Given this list of marker genes MACROH2A1, FANCM, ADAMTS3, SLCO5A1, ZFYVE27, IKBKB, ATAD5, CKAP2, DHFR, MRPL51, UBR5, MRPL20, UBE2T, API5, AKAP5, SMC2, TMPO, KRBOX1, NCAPG, DNTTIP2, XRCC3, ZNF330, ERCC1, HJURP, TOP2A, DLGAP5, MSH5, MTERF1, NDUFA9, CHAF1A, WDR83OS, CDKN3, MND1, RPS26, RGS6, PCDHB5, ZNF532, LAMA1, POLE2, HAND2, ESPL1, RGS16, ODF2, ITFG2, LSS, SGO2, ZWINT, PARPBP, GIT2, KIF15, RBMY1A1, INF2, CCT6A, SAP30, ANLN, SPC25, HYCC1 (NCBI Gene Id 84668), ERH (NCBI Gene Id 95660), MRPL42, RPA3, CENPF, GJC1, HMGB2, PINX1, MACIR, TGFB3, PSIP1, CDC6, RIC8B (NCBI Gene Id 55188), DAP3, TCOF1, SPCS3, CCNA2, ZNF93, FGFR1OP2, ATAD2, CHEK1, RBM17, LARP4, ZNF146, FANCD2, BRIP1, ARHGAP11A, CTPS1, HOMER1, PRPF40A, OR2A4, PCLAF, PSTPIP1, NAA15, KIF2C, PPP4R3A (protein phosphatase 4 regulatory subunit 3A), DBF4, CEP55, SNRPD3, NAMPT, EAF1, RGS1, LMNB1, H2AZ1, XPO4, C4orf3, CSRNP1, KPNA2, ANK2, WDHD1, PTTG3P, HMGN2, PAG1, MELK, BRD9, GMNN, CLPTM1L, SDCBP, CENPK, PDE4A, PROSER1, RAN, SYNCRIP, TBC1D31, POLR2F, MPHOSPH8, NDC80, SNRPD1, DAZAP1 (DAZ associated protein 1), TPX2, CLCN5, CASP4 (NCBI Gene Id 837), NCAPH, CEP83, GPAT4, KNL1, CHD1, KNTC1, NCAPD2, PIGS, LSM5, NDC1, MGAT4C, THOC5 (THO complex subunit 5), BLM, CENPU, BRCA1, MCM3AP, SNRPA1, POLQ, ATP2B3, STX1A, CCNB1, PIF1, NOP58, DSCC1, KIF23, NUSAP1, NCKAP1L, KIF18A, CENPE, NCAPG2, PDYN, ESF1 (NCBI Gene Id 55639), FEN1, GDAP1, EP400, CHTF18, here is a description of the gene set: Human Gene Set: FERREIRA_EWINGS_SARCOMA_UNSTABLE_VS_STABLE_UP Ewing's sarcoma (ES) is characterized by specific chromosome translocations, the most common being t(11;22)(q24;q12). Additionally, other type of genetic abnormalities may occur and be relevant for explaining the variable tumour biology and clinical outcome. We have carried out a high-resolution array CGH and expression profiling on 25 ES tumour samples to characterize the DNA copy number aberrations (CNA) occurring in these tumours and determine their association with gene-expression profiles and clinical outcome. CNA were observed in 84% of the cases. We observed a median number of three aberrations per case. Besides numerical chromosome changes, smaller aberrations were found and defined at chromosomes 5p, 7q and 9p. All CNA were compiled to define the smallest overlapping regions of imbalance (SORI). A total of 35 SORI were delimited. Bioinformatics analyses were conducted to identify subgroups according to the pattern of genomic instability. Unsupervised and supervised clustering analysis (using SORI as variables) segregated the tumours in two distinct groups: one genomically stable (< or =3 CNA) and other genomically unstable (>3 CNA). The genomic unstable group showed a statistically significant shorter overall survival and was more refractory to chemotherapy. Expression profile analysis revealed significant differences between both groups. Genes related with chromosome segregation, DNA repair pathways and cell-cycle control were upregulated in the genomically unstable group. This report elucidates, for the first time, data about genomic instability in ES, based on CNA and expression profiling, and shows that a genomically unstable group of Ewing's tumours is correlated with a significant poor prognosis. studied in species Homo sapiens from publication Ferreira BI, Alonso J, Carrillo J, Acquadro F, Largo C, Suela J, Teixeira MR, Cerveira N, Molares A, Goméz-López G, Pestaña A, Sastre A, Garcia-Miguel P, Cigudosa JC (PMID 17952124) Genes up-regulated in genomically unstable Ewing's sarcoma tumors compared to the stable ones.